The following is a description of a gene set: Although, DNA replication occurs in the S phase of the cell cycle, the formation of the DNA replication pre-initiation complex begins during G1 phase. part of: DNA Replication Reactome Pathway: DNA Replication Pre-Initiation studied in species Homo sapiens, and this is the list of marker genes: ANAPC1, H2BC11, H2BC14, H2BC15, RPA3, H2AC14, UBB, PSMA7, CDC6, CDT1, ORC3, PSMD13, PSMD6, PSMA1, PSMD3, MCM6, POLE2, PSMB1, H2AC18, RPS27A, POLA2, PSMC4, PSMC3, MCM5, KPNA6, H2BC3, ANAPC2, PSMD1, ANAPC11, H3-3A, H2BC21, UBC, PSMC6, UBE2E1, PSMC1, PSMB4 (proteasome 20S subunit beta 4), PSMC5, UBE2S (ubiquitin conjugating enzyme E2 S), PSMA3, GMNN, PSMD2, H2AC6, PSMD7, MCM7 (NCBI Gene Id 4176, minichromosome maintenance complex component 7), ORC6, H2AX (H2A.X variant histone), PSMA2, UBE2C, ANAPC5, H2AC4, POLE3, ANAPC10, ORC4, RPA2, ANAPC4, H2AB1, CDC7, H2BC12, POLE4, DBF4, PSMD14, MCM4, PSMD11, H2AJ (NCBI Gene Id 83739), H2BC26, CDK2, H2BC5, CDC26, H2BC17, PSMD8, ORC2, H3C1, H2BC12L, CDC16, H2AC20, KPNA1, MCM10, POLA1, PSMD12, PSMA6 (proteasome 20S subunit alpha 6), MCM2, H2AZ2, H2BC13, ANAPC7, PSMA5, PSMC2, MCM3, CDC27, RPA4, ORC1 (origin recognition complex subunit 1), CDC45, POLE, H4C1, PSMB5 (proteasome 20S subunit beta 5), H2BC1, ANAPC15, PRIM2, PSMB2 (proteasome 20S subunit beta 2), CDC23, KPNB1, H2BC9, UBA52, PSMA4, H3C15, PSMB3, UBE2D1, H2AC7, MCM8, ADRM1, PRIM1, PSMB6, SEM1, FZR1, ORC5, H2BC4, PSMB7, ANAPC16, RPA1